Given this list of marker genes SLC6A8, SLITRK2, DIAPH2, IGBP1, GK (NCBI Gene Id 2710), UBE2A, MID2, BCORL1, BMP15 (bone morphogenetic protein 15), ELF4, NSDHL, SMPX, PTCHD1, MAMLD1, TIMM8A, KDM5C, WAS, IKBKG, SRY, PORCN, CUL4B, CCNQ, LAMP2, FANCB, DLG3, OPN1MW, AVPR2, IQSEC2, PCDH19, COL4A5, GPRASP2, SRPK3, ARL6, NEXMIF, POF1B, TSR2, OCRL, EFNB1, SLC35A2, AIFM1, NLGN4X, TCEAL1, GPC4, ATP11C, HPRT1, CNKSR2, GJB2, PIGA, PHF6, MBTPS2, ALG13 (ALG13 UDP-N-acetylglucosaminyltransferase subunit), COX7B, G6PD, EMD, AMER1, TAF1, PQBP1 (polyglutamine binding protein 1), DOCK11, OPHN1, CSF2RA, ACSL4, PAK3, C1GALT1C1, ATP6AP1, SH2D1A, ZFX, STS, DDX3X (DEAD-box helicase 3 X-linked), ZIC3, DKC1, LAGE3 (NCBI Gene Id 8270), FAM50A, NDUFA1, CHRDL1, SASH3, ARR3, HS6ST2, L1CAM, NDP, SH3KBP1, TSPAN7, AP1S2, LAS1L, NYX, ZMYM3, NKAP, AMMECR1, WDR45, USP27X, PHKA1, ABCD1, FGF13, FLNA, VMA21, ATRX, CYBB, IDS, EBP (EBP cholestenol delta-isomerase), BTK, ATP7A, FRMPD4, OTC, MTM1, MCTS1, IRS4, PHEX, TMLHE, NAA10 (NCBI Gene Id 8260), CLCN4, ARHGEF9, HDAC6, PGK1, RBM10, GJB1, FGD1, IL1RAPL1, COL4A6, SYN1, SOX3, CACNA1F (calcium voltage-gated channel subunit alpha1 F), PDK3, STEEP1, LRAT, SMS, ATP6AP2, MAGT1, SSX1, TRAPPC2, DNAAF6, CSTF2, PLP1, SMC1A, UBA1, RLIM, CNGA1, PHF8, ANOS1, CFP, GLA, OFD1, PRICKLE3, HUWE1, SLC16A2, MSL3, CD40LG, BCAP31, DMD, SPIN4, RNF113A, OPN1LW, MED12, ROM1, PHKA2, PRPS1, ALAS2, RPGR, ATP2B3, CDKL5 (cyclin dependent kinase like 5), CLCN5, CYLC1, XK, RP2, GPR143, TEX11, EDA, CLRN1, TLR7, GLRA2, GPR101, NDUFB11, BCOR, KDM6A, USP26, ZNF711, FHL1, UPF3B, HMGB3, CCDC22, IL2RG, RS1, RPS6KA3, FOXP3 (forkhead box P3), CFAP47, SHOX, AIPL1, GABRA3, ARSL, MID1, THOC2, FRMD7, AR, CRB1, BRWD3, HNRNPH2, MECP2, ABCB7, TAFAZZIN, CFAP418, BGN, GJB6, ARX, UBQLN2, POU3F4, GPC3, HDAC8, FGF16, OTUD5, CRX, MAGED2, POLA1, TFE3 (NCBI Gene Id 8244), USP9X, CASK, F8, RAB39B, STAG2, AFF2, NLGN3, KLHL15, TBC1D8B, EIF2S3, GCNA, GRIA3, PDHA1, HSD17B10, MSN, NHS, GDI1, TBL1X, KIF4A, FTSJ1, CLDN2, SLC9A6, CT55, IGSF1, HCFC1, ZC4H2, XIAP, SSR4, CHM, PDE6G, AMELX, WNK3, MAOA, NONO, F9, ZDHHC9, OGT, TLR8, NR0B1, DCX, SYP, FMR1, RBP3, SLC9A7, GATA1, RPL10, TBX22, ADGRG2, RBMX, HCCS, here is a description of the gene set: A mode of inheritance that is observed for traits related to a gene encoded on the X chromosome. Human Gene Set: HP_X_LINKED_INHERITANCE X-linked inheritance species: Homo sapiens